The following is a description of a gene set: studied in species Homo sapiens Human Gene Set: VANTVEER_BREAST_CANCER_METASTASIS_DN Genes whose expression is significantly and negatively correlated with poor breast cancer clinical outcome (defined as developing distant metastases in less than 5 years). from publication van 't Veer LJ, Dai H, van de Vijver MJ, He YD, Hart AA, Mao M, Peterse HL, van der Kooy K, Marton MJ, Witteveen AT, Schreiber GJ, Kerkhoven RM, Roberts C, Linsley PS, Bernards R, Friend SH (PMID 11823860) Breast cancer patients with the same stage of disease can have markedly different treatment responses and overall outcome. The strongest predictors for metastases (for example, lymph node status and histological grade) fail to classify accurately breast tumours according to their clinical behaviour. Chemotherapy or hormonal therapy reduces the risk of distant metastases by approximately one-third; however, 70-80% of patients receiving this treatment would have survived without it. None of the signatures of breast cancer gene expression reported to date allow for patient-tailored therapy strategies. Here we used DNA microarray analysis on primary breast tumours of 117 young patients, and applied supervised classification to identify a gene expression signature strongly predictive of a short interval to distant metastases ('poor prognosis' signature) in patients without tumour cells in local lymph nodes at diagnosis (lymph node negative). In addition, we established a signature that identifies tumours of BRCA1 carriers. The poor prognosis signature consists of genes regulating cell cycle, invasion, metastasis and angiogenesis. This gene expression profile will outperform all currently used clinical parameters in predicting disease outcome. Our findings provide a strategy to select patients who would benefit from adjuvant therapy., and this is the list of marker genes: HJURP, SYNCRIP, MAPRE2, MGAT4A (alpha-1,3-mannosyl-glycoprotein 4-beta-N-acetylglucosaminyltransferase A), DTL, CA9, ECT2, ASNS, DLGAP5, RAD21, TK1, TMEM65, ESM1, PFKP, PLAAT1, VEGFA, RRAGD, MELK, MTDH, NMB, PSMD2, OXCT1, PSMD7, KIF21A, PITRM1, CDK16, CP, MCCC1, GNAZ, CENPA, STK3, CDC42BPA, PIR, SMC4, MTMR2, MRPL13, COL4A2, HMGB3, IVNS1ABP, SLC2A3, DIAPH3, DENND11, CTPS1, NMU, RAB6B, GBE1, MMP9, ORC6, CMC2 (C-X9-C motif containing 2), ADM, BNIP3, TFRC, SERF1A, TMEM74B, SPC25, EXT1, CTSV, CKS2 (CDC28 protein kinase regulatory subunit 2), AGFG1, PAQR3, BIRC5, DCK, NDC80, MCM6, CCNB2, PGK1, PRC1, NDRG1, PIMREG, PLEKHA1, LPCAT1, FLT1, LRP12, PTDSS1, GPSM2, DEGS1, PALM2AKAP2, CDC25B, TSPYL5, INAVA, CENPN, INTS7, HACD2, ATAD2, CCNE2, GGH, ARMC1, TRIP13, STMN1 (NCBI Gene Id 3925), KIF14, GMPS, BUB1, UCHL5, SLC7A1, SACS, DEPDC1, MAD2L1, FBXO5, AURKA, TMEM45A, ASPM, STX1A, RFC4, EZH2, PRAME, NUSAP1, IGFBP5, MLLT10, ADGRG6 (adhesion G protein-coupled receptor G6)